Given this list of marker genes Rhbg, Slc6a18, Slc41a1, Slc11a2, Slc16a7, Slc30a5, Slc6a13, Slc39a4, Slc44a5, Slc6a9, Slc11a1, Slc6a15, Slc5a3, Slc39a6, Slc41a2 (solute carrier family 41, member 2), Slc6a7, Slc44a2, Slc6a14, Slc13a4, Cp, Slc6a11, Emb, Slc5a11, Slc22a18, Slc22a15, Slc22a1, Slc6a19 (NCBI Gene Id 74338), Slc22a2, Slc30a8, Slc39a3, Slc22a5, Rhag, Slc13a1, Slc6a5, Slc31a1, Slc6a3, Slc16a1, Slc22a4, Rhcg, Slc22a3, Slc40a1, Slc16a3, Slc22a8, Slc22a7, Slc22a6, Slc2a13, Slc10a6, Slc6a2, Slc14a1, Slc47a1, Slc30a10, Slc39a7, Slc14a2, Slc6a20a, Slc39a8, Slc13a2 (solute carrier family 13 (sodium-dependent dicarboxylate transporter), member 2), Slc44a3 (NCBI Gene Id 213603), Slc18a1, Heph, Slc44a1, Slc39a14, Slc13a3, Slc13a5, Slc39a2, Slc44a4, Slc30a1, Slc6a6, Slc39a1, Slc22a16, Bsg, Slc6a12, Slc5a7, Slc16a8, Slc6a1, Slc22a12 (solute carrier family 22 (organic anion/cation transporter), member 12), Slc18a2, here is a description of the gene set: species: Mus musculus Mouse Gene Set: REACTOME_TRANSPORT_OF_BILE_SALTS_AND_ORGANIC_ACIDS_METAL_IONS_AND_AMINE_COMPOUNDS Transport of bile salts and organic acids, metal ions and amine compounds